The following is a description of a gene set: species: Homo sapiens Human Gene Set: MODULE_534 Genes in the cancer module 534., and this is the list of marker genes: CENPE, DUSP16 (dual specificity phosphatase 16), H2BC11, SCNN1B, H2BC21, H2AC8 (NCBI Gene Id 3012), DNAJC1, H2BC13, HMGB2 (high mobility group box 2), SNHG12, H2AC18, H2BC12 (NCBI Gene Id 85236), RUSF1, DIP2C, H1-2 (NCBI Gene Id 3006), SLC22A23, SEC14L1, CENPA